The following is a description of a gene set: Human Gene Set: MIR6837_3P Genes predicted to be targets of miRBase v22 microRNA hsa-miR-6837-3p in miRDB v6.0 with MirTarget v4 prediction scores > 80 (high confidence targets). from publication Chen Y, Wang X (PMID 31504780) studied in species Homo sapiens, and this is the list of marker genes: TAB2, DCUN1D5, N4BP1, TBR1, ANKRD37, LUC7L3, VGLL3, SUDS3, ASF1A, ZNF99, ALDH8A1, SUB1, CDHR3, CNOT2, GAS7, FAM3B, GCA, EIF3J, GDI2, ZNF107, HPCAL4, CREBRF, CNR1, KMT2D, ZNF765, GRHL1, ARHGEF38, CRACD, JCAD, HLTF, E2F5, ZMIZ2, RRM2B, RAP1A, TMEM181, CD302, ETNK1, CLTC, VRK2, CORT, BEX1, NAPG, VAMP4, ST6GALNAC1, CADM1, ZNF117, ZNF404, LRRFIP2, PDE7A, KIF1C, TMEM164, WNK4, LRRC7, POP4, TC2N, RFT1, ZNF257, TOPORS, LGI1, TMEM70, PURA, CAMTA2, COL25A1, CPEB2, CALCR, IL7R, CASP4, UQCC1, ESM1, PSD3, TRIP12, IRF6, DNAH14, RBM27, RNFT1 (ring finger protein, transmembrane 1), ATRN (NCBI Gene Id 8455), RBM47, ZNF680, CMA1, CASP14 (caspase 14), ADAM12, CENPS-CORT, LRRC49, MEOX2, CSNK1A1, ACSL1, IGFBP5, RELCH, LHFPL2, HNRNPK, ARHGAP5, EPHB1, MAPK6, THAP6, LY75-CD302, ZNF208, NDFIP2, MYOCD, ELAVL1, ZNF100, ABCD3, TNFAIP3, ZNF493, EDAR, POT1, BTG1, CCDC141 (NCBI Gene Id 375296)